Given this list of marker genes PSMC5, PSMD4, RAD23B (RAD23 homolog B, nucleotide excision repair protein), PIGT, PSMB7, PSMA6, ZFAND2B, PSMB5, CASP2, PSMB8, CAPNS2, PSMD11, ZFAND2A, PSMB11, VCP, PSMD14, SEM1, PSMC6 (NCBI Gene Id 63380), USP14, CASP9, SEC11A, HTRA2, HSPB1, PSMB2, TXNL1, SEC11B (SEC11 homolog B, signal peptidase complex subunit (pseudogene)), PSMD7, PSMC3, COLEC11, CAPNS1, PSME3, PSMD13, PSMD2, FCN2, PSME1, PSMA4, PSMB3, ADRM1, PIGK, UCHL5 (NCBI Gene Id 82736), SPCS3, FCN3, PSMB6, PSMC1, CAPN1, PSMD12, SEC11C, PLAU, IMMP2L, PIDD1 (p53-induced death domain protein 1), FCN1, PRICKLE1, CAPN2 (calpain 2), PSMC4, PSMB9, PIGS, IMMP1L (inner mitochondrial membrane peptidase subunit 1), PMPCB, PSMC2, PSMB4, PSMD5, PMPCA, PSMD9, UBE3C, SPCS1 (signal peptidase complex subunit 1), PSMD6, PSMD10, PSMA5, RAD23A, SPCS2, DNAJB2, PSMB10, THBD, PSMA7, PAAF1, UBE3A, IDE, PSMA3, PLAUR, PSMD8, GPAA1, PSMD1, PSMD3, PSMA1, ECPAS, PSME4, PSME2, COLEC10, PIGU, PSMB1, CFH (complement factor H), UBQLN1, CRADD, PSMA2, MBL2, UBR1, PSMF1, PSMA8, UBQLN4, here is a description of the gene set: species: Homo sapiens A protein complex which is capable of endopeptidase activity. Human Gene Set: GOCC_ENDOPEPTIDASE_COMPLEX